Given this list of marker genes Plod2, Xdh, Id3, Prrx1, Msln, Rgs2, Add3, Cebpd, Errfi1, Kitl, Eno2, Cdh26, Fdx1, Six1, Rnf144a, Gas2, Pxylp1, Ramp3, Alcam, Id2, Nr3c1, Egln3, Fndc3a, Sipa1l2, Pde8b, Tob2, Tenm4, Sgpp1, Vip, here is a description of the gene set: The Runx genes are important in development and cancer, where they can act either as oncogenes or tumour suppressors. We compared the effects of ectopic Runx expression in established fibroblasts, where all three genes produce an indistinguishable phenotype entailing epithelioid morphology and increased cell survival under stress conditions. Gene array analysis revealed a strongly overlapping transcriptional signature, with no examples of opposing regulation of the same target gene. A common set of 50 highly regulated genes was identified after further filtering on regulation by inducible RUNX1-ER. This set revealed a strong bias toward genes with annotated roles in cancer and development, and a preponderance of targets encoding extracellular or surface proteins, reflecting the marked effects of Runx on cell adhesion. Furthermore, in silico prediction of resistance to glucocorticoid growth inhibition was confirmed in fibroblasts and lymphoid cells expressing ectopic Runx. The effects of fibroblast expression of common RUNX1 fusion oncoproteins (RUNX1-ETO, TEL-RUNX1 and CBFB-MYH11) were also tested. Although two direct Runx activation target genes were repressed (Ncam1 and Rgc32), the fusion proteins appeared to disrupt the regulation of downregulated targets (Cebpd, Id2 and Rgs2) rather than impose constitutive repression. These results elucidate the oncogenic potential of the Runx family and reveal novel targets for therapeutic inhibition. Common target genes down-regulated by all three Runx family members (RUNX1, RUNX2, and RUNX3) in MEF cells (embryonic fibroblasts). studied in species Mus musculus Mouse Gene Set: WOTTON_RUNX_TARGETS_DN from publication Wotton S, Terry A, Kilbey A, Jenkins A, Herzyk P, Cameron E, Neil JC (PMID 18560354)